Given this list of marker genes Isl1, Casp1, S100a13, Nlrp10, Ccl20, Il16, Panx1, P2rx7, here is a description of the gene set: species: Mus musculus Mouse Gene Set: GOBP_POSITIVE_REGULATION_OF_INTERLEUKIN_1_ALPHA_PRODUCTION Any process that activates or increases the frequency, rate, or extent of interleukin-1 alpha production.